The following is a description of a gene set: Genes having at least one occurrence of the motif NSTGACGTAANN in the regions spanning 4 kb centered on their transcription starting sites. This matches the CREB1 transcription factor binding site V$CREB_Q2 (v7.4 TRANSFAC). Human Gene Set: CREB_Q2 species: Homo sapiens, and this is the list of marker genes: LTBP1, CSTF3, WFDC3, MYL6, SENP2, CEP57, GEM, CRELD1, MRC2, TMEM39A, CREM, PSENEN, PABPC1, RPRD1A, JOSD1, TCEAL9, MAFF, COL5A3, PER1, BNIP3L (BCL2 interacting protein 3 like, NCBI Gene Id 9257), CNTROB, ADISSP, CCDC148, TGIF2, KIF17, AHI1, VPS37B, CDC14B, RAB3A, ZFYVE27, GTF2A1, CLDN7, RNF44, HHIP, ELOVL5, SLC25A37, RAI1, GPBP1, BUD31, CHAC1, FAM167A, RING1, GNL1, PAK3, NR4A3, PNPLA3, MBNL2, DNAJB2 (NCBI Gene Id 3300), ASPHD1, SMARCD1, CCN4, RBBP8, PNRC1, OSBPL9, C11orf87, CHPF, FXR2, NDUFA10, PRELID1, U2AF1L4, SCG2, PENK, NFKBID, CLCN3, FGF6, FOXD3, NOL4, GADD45B, RELB, TEX14, SGIP1, DNAJC9 (NCBI Gene Id 23234), RCAN1, TLE3, OGDH, TRIB1, PCSK1, GJD2, EPHA2, IFT57, ATF1 (NCBI Gene Id 466), HOXC10, PFAS, FBXL2, CYSTM1, ZNF711 (zinc finger protein 711), HERPUD1, TAGLN2, CYLD, SLC66A2, NEUROD6, PTPRU, GNAS, PNMA3, SRCIN1, PNMA6A, DACT1, NR4A2, DAAM2, CRH, HS3ST3A1 (heparan sulfate-glucosamine 3-sulfotransferase 3A1), TSC22D2, PPIG, CXCL16, HDX, MAP3K7 (NCBI Gene Id 6885), RFX5, ARIH1, HHEX, CACNB2, MAP3K13 (NCBI Gene Id 9175), SSTR2, DDX51, EGR1, ORMDL2, CMSS1, TBC1D32, FGF9, SLC18A2 (solute carrier family 18 member A2), ITFG2, MAP1LC3A, SPATA7, AGPAT1, PTP4A1, SST, SLC31A1, NR6A1, TMEM175, SDHB, ZZEF1, RBMS2, NTRK2, IKBKB, RUNDC3A, JAG1, SRSF1, ALDH18A1, RUSC1-AS1, ZNF367, TAFA1, CAMK2D, RPS6KA3, FOSB, CTCF, C1orf35, CALM2, NR3C1, ZNF184, ELAVL1, C6orf62, LDHA, PTGES3, UBQLN2, SARNP, ZBTB20, LGR5, RAB7A, NOC4L, EGR3, SMS, PAFAH1B1, PLSCR3, MAF, LMTK2, ADAP1, NUBPL, MRRF, ZMYND15, CD2AP, TPM4, SIK2, GRM3, NUP98, PKP4, DDX3X, KIF7, SLC38A1, ZBTB37, NINJ1, ING3, ZNF516-DT, ZC3H10, ZBTB21, GTF3C1, SYNGR3, HNRNPA2B1, ATP6V0C, ARL4D, TP53INP2, IRX6, NPTX1, GPM6B, RAB25, CDC42, PDAP1, TMUB2, GAK, ZNF687, RBP5, SIK1, KCNA5 (potassium voltage-gated channel subfamily A member 5), NR2E1, PITX2, TSC22D3, ATG5, GLYR1, TRIM39, DHX36, ALKBH5, ID1, YJU2B, RNF5, ADAM9 (NCBI Gene Id 8754), DPH3, HS3ST2, TMEM86A, PLK4, FSTL5, CLSTN3, STAT3, RUSC1, RAB6A, MARCHF6, ATF3, ERF, KLF13, TLNRD1, NFATC1, PHACTR3, PPARGC1A, BRAF, NUDT3, UCN, CDK2AP2, DUSP1, TAOK2 (NCBI Gene Id 9344), CBX3 (NCBI Gene Id 82756), OSR1, PDP1, TM2D2, EGR4, TSPAN7, IRX4, KNL1, ADCY8, RAB24, FAM131A, EIF1, SCAMP5, ABHD16A, SMAD1, OXNAD1, CMTR1, PPP2R5B, LMCD1, ETF1, AKIRIN1, PPP1R15A, H4C5 (H4 clustered histone 5), WNT10A, SREBF2, RPL41, IRF2BPL, CHGB, FOS, NDST1, PRR3, EVX1, SEMA4C